Given this list of marker genes RSPO2, HEATR3, RPS27, FGFR3, RIPK4, ERCC4, FANCB, FANCE, RPS7, RPL9 (NCBI Gene Id 6133), RAD51C, RPL35, RPS20, GATA1, VAC14, RAD51, RPS19, DONSON, RPS17, SF3B4, SLX4, RPL11, RBM8A, RECQL4, RPL26, FANCD2, ADA2, FGF10, SON, RPL31, PALB2, RPS10, FGFR2 (fibroblast growth factor receptor 2), FANCF, FANCC, FANCA, TBX5, RFWD3, SALL4, RPS15A, ESCO2, FIG4, RPL18, RPS29, PSMD12, RPL5, RPS24, RPS28, RPL15, XRCC2, TSR2, RPL27, CUL3, RPL35A, FANCI, FANCL, RPS26, RPL8, here is a description of the gene set: species: Homo sapiens Absent thumb, i.e., the absence of both phalanges of a thumb and the associated soft tissues. Human Gene Set: HP_ABSENT_THUMB Absent thumb